The following is a description of a gene set: Human Gene Set: KEGG_MEDICUS_VARIANT_LMO2_REARRANGEMENT_TO_TRANSCRIPTIONAL_ACTIVATION LMO2-rearrangement to transcriptional activation. Pathway ID: N00121. Pathway type: Variant. Pathway class: nt06240 Transcription. Pathway Definition from KEGG: (LMO2*+LDB1) == (LYL1+TCF3) => HHEX species: Homo sapiens, and this is the list of marker genes: HHEX, LMO2, LDB1, TCF3, LYL1 (LYL1 basic helix-loop-helix family member)